The following is a description of a gene set: studied in species Homo sapiens from publication Dhodapkar KM, Banerjee D, Connolly J, Kukreja A, Matayeva E, Veri MC, Ravetch JV, Steinman RM, Dhodapkar MV (PMID 17502666) The ability of dendritic cells (DCs) to activate immunity is linked to their maturation status. In prior studies we have shown that selective antibody-mediated blockade of inhibitory FcgRIIB receptor on human DCs in the presence of activating immunoglobulin (Ig) ligands leads to DC maturation and enhanced immunity to antibody-coated tumor cells. Here we show that Fcg receptor (FcgR) mediated activation of human monocytes and monocyte-derived DCs is associated with a distinct gene expression pattern, including several inflammation associated chemokines as well as type 1 interferon (IFN) response genes including the activation of signal transducer and activator of transcription 1 (STAT1). Human Gene Set: GSE7509_DC_VS_MONOCYTE_DN Genes down-regulated in dendritic cells versus monocytes., and this is the list of marker genes: EPB41L4A, SLC7A7, TSEN34, FLOT2, GMFG, PTGIR, KCNJ3, SAYSD1 (NCBI Gene Id 55776), IFIH1, HLA-DRB1, TBP, INHBA, PMP22, CLEC4E, CFAP68 (NCBI Gene Id 737), USP18, ECI2, TPST1, STAB1, LIN9, HCK, RHOB, ENO1, ADA, TANC1, PCDHA11, SNRNP40, TNFRSF1B, FSTL3, KRTCAP2, GIMAP4, ACOD1, SNX13, RWDD4, ANXA2, RBM10, PRP4K, TPM3, LPCAT3, TNF, SUZ12, NCK1 (NCBI Gene Id 4690), ZNF688, SLC7A11, STX8, TMEM50B, SAA1, ZBED3, CRYBG1, TRAF1, SLC25A14, CCN5, XBP1, SEMA4D, IFIT3, CASP4, AQP1, SDHAF1, PRPF38A, RAB33B, TK2, RGS14, CLCNKB, GLRX, ZNFX1, SRXN1, CYBB, ABCG1, NFKBIA, OR2H1, ATF4, SEC14L2, CEBPG, ABHD16A, ALDOA, HLA-DQA1, NUP35, C3, KLF3, FPR1, RAP1GAP, IFI35, RANBP1, NPL, CSNK2A1, MARVELD1, GPR137B, FGR, FIGNL1, KLF4, COASY, MAGOH, TXN, U2AF1L4, FKBP1B, TAP1, CPT1A, AUP1, SHISA5, CD47, ZNF865, SRSF6, ALDOAP2, PLAA, S100A8, ZNHIT1, LGALS3BP, DMTN, CMPK2, ETS2, TSKU, GHRL, SPCS1, MARCO, MOB1B, GSTA3, ORC5, PDIA5, AQP9 (NCBI Gene Id 366), ACSL1, CCRL2, HP, PSME2, AGPAT5 (1-acylglycerol-3-phosphate O-acyltransferase 5), STAT1, MX2, DNAAF10, PWP1, CCR6 (NCBI Gene Id 1235), ACP5, TSC22D4, GBP2, RNASET2 (ribonuclease T2), PROCR, CXCL3, FCGR1A, NAB1, RGCC, THOC3, F10, TSPO, RAF1, INPP4A (NCBI Gene Id 3631), CBLN1, IER2, OLR1, NUPR1, PSEN1, PSMB9, MS4A1, LY6E, TM9SF1, PTGES, GCLM, NEFM, CA6, PRDX1, SMPD1, MAIP1, CD14, MTDH, GORASP2, CD302, RHOA, HUS1, SOD2, RHO, CLCN5, RARG, SLPI, SPI1, PDIA3, FPR2, SNX10, AGRN, CYB5A, CXCL10, IRGM, HTRA3, ACAA1, ACP2, CBR3, EZR, CR1L, KLF7, KIAA2013, GUCD1, GALNT1, TXN2, NUDT3, PRELID1, PNP, NR1H3, PPP2R5D, C1orf52, NEUROG3, NOTCH4, KLF2, CLIC4, SLFN12 (schlafen family member 12)